The following is a description of a gene set: The stepwise addition of carbohydrate or carbohydrate derivative residues to the initially added O-linked residue (usually GalNAc) to form a core O-glycan structure. studied in species Mus musculus Mouse Gene Set: GOBP_O_GLYCAN_PROCESSING, and this is the list of marker genes: Galnt10, Gxylt2, Gxylt1, Galnt2, Gcnt1 (NCBI Gene Id 71444), C1galt1, Xxylt1, Pomgnt1